Given this list of marker genes TLR6, TLR4, TREM2, TICAM1 (NCBI Gene Id 148022), CD68, MIR146A, AKT1, SMPD3 (sphingomyelin phosphodiesterase 3), MIR20A (NCBI Gene Id 406982), ADTRP, MIA3 (MIA SH3 domain ER export factor 3), MYD88, TXNIP, CD36, here is a description of the gene set: Human Gene Set: GOBP_CELLULAR_RESPONSE_TO_OXIDISED_LOW_DENSITY_LIPOPROTEIN_PARTICLE_STIMULUS Any process that results in a change in state or activity of a cell (in terms of movement, secretion, enzyme production, gene expression, etc.) as a result of an oxidized lipoprotein particle stimulus. studied in species Homo sapiens